The following is a description of a gene set: Mouse Gene Set: CUI_NK_CELL_TSLP_RESPONSE_UP from publication Cui A, Huang T, Li S, Ma A, Pérez JL, Sander C, Keskin DB, Wu CJ, Fraenkel E, Hacohen N (PMID 38057668) Cytokines mediate cell-cell communication in the immune system and represent important therapeutic targets. A myriad of studies have highlighted their central role in immune function, yet we lack a global view of the cellular responses of each immune cell type to each cytokine. To address this gap, the authors created the Immune Dictionary, a compendium of single-cell transcriptomic profiles of more than 17 immune cell types in response to each of 86 cytokines (>1,400 cytokine-cell type combinations) in mouse lymph nodes in vivo. A cytokine-centric view of the dictionary revealed that most cytokines induce highly cell-type-specific responses. For example, the inflammatory cytokine interleukin-1β induces distinct gene programmes in almost every cell type. A cell-type-centric view of the dictionary identified more than 66 cytokine-driven cellular polarization states across immune cell types, including previously uncharacterized states such as an interleukin-18-induced polyfunctional natural killer cell state. Genes positively differentially expressed in cell type: NK cell upon treatment with cytokine: TSLP in mouse lymph nodes in vivo. species: Mus musculus, and this is the list of marker genes: Usp34 (ubiquitin specific peptidase 34), Jaml, Psph, Fam117b, Lsm10, Rap1a, Pam16, Smad2, Gipc1, Gtf3a, Zdhhc16, Sytl3, Hsd11b1, Tmem14c, Lgals3, Sdcbp